The following is a description of a gene set: The pathogenesis of incipient Alzheimer's disease (AD) has been resistant to analysis because of the complexity of AD and the overlap of its early-stage markers with normal aging. Gene microarrays provide new tools for addressing complexity because they allow overviews of the simultaneous activity of multiple cellular pathways. However, microarray data interpretation is often hindered by low statistical power, high false positives or false negatives, and by uncertain relevance to functional endpoints. Here, we analyzed hippocampal gene expression of nine control and 22 AD subjects of varying severity on 31 separate microarrays. We then tested the correlation of each gene's expression with MiniMental Status Examination (MMSE) and neurofibrillary tangle (NFT) scores across all 31 subjects regardless of diagnosis. These well powered tests revealed a major transcriptional response comprising thousands of genes significantly correlated with AD markers. Several hundred of these genes were also correlated with AD markers across only control and incipient AD subjects (MMSE > 20). Biological process categories associated with incipient AD-correlated genes were identified statistically (ease program) and revealed up-regulation of many transcription factor/signaling genes regulating proliferation and differentiation, including tumor suppressors, oligodendrocyte growth factors, and protein kinase A modulators. In addition, up-regulation of adhesion, apoptosis, lipid metabolism, and initial inflammation processes occurred, and down-regulation of protein folding/metabolism/transport and some energy metabolism and signaling pathways took place. These findings suggest a new model of AD pathogenesis in which a genomically orchestrated up-regulation of tumor suppressor-mediated differentiation and involution processes induces the spread of pathology along myelinated axons. Human Gene Set: BLALOCK_ALZHEIMERS_DISEASE_UP species: Homo sapiens from publication Blalock EM, Geddes JW, Chen KC, Porter NM, Markesbery WR, Landfield PW (PMID 14769913) Genes up-regulated in brain from patients with Alzheimer's disease., and this is the list of marker genes: CPSF1, FZR1, APOL2, ZNF202, PTGS1, ZMYM2, EDF1, TENT5A, KAT6A, MITF, TCF7L2, GDF9, KIF2C, NUP98, EPS8, RRBP1, ADGRA3 (adhesion G protein-coupled receptor A3), GPC4, NCSTN, MICB, LAMA2, UPF3A, PIK3C3, HBP1, CHD1, PPP2R5D, SSH3, KCNK5, ARHGEF15, TAF15, TLR1, ZNF268, PDLIM4 (NCBI Gene Id 8572), PPP1R15A, ZNF253 (NCBI Gene Id 56242), PRPF40A, PBX2P1, LAMP1, SPTLC2, SRPX, YY1 (YY1 transcription factor), CYP39A1, CSNK1A1, SNHG14, RBM4B, TPTE, ERP44, SFXN3, PPFIA1 (NCBI Gene Id 8500), MPST, BMPR1A, ELSPBP1, RAC1, LRP6, HDAC1, TAF5, PTP4A2, ADCY7, MAFB, MBP, EXOSC2, ANXA2, HAO2, MAX, RNF24, TNC, COPB1, COL18A1, SLC7A5, TAF11, OFD1, BCL2, RGS9, GBP2, SFSWAP, ZMYM4, TFAP2A, SPAG1, OSER1, SLC13A1, CTDSP2, UCN, ADD3, PNISR (NCBI Gene Id 84956), GYPB, TGFBR3, ZNF133, TTN, PCSK5, ADCY3, SFRP4, RAB3GAP1, GOLIM4, ITGB5, ETV7, PZP (PZP alpha-2-macroglobulin like), PDLIM2, ELK1, GOLGB1, LUC7L3, RER1, FA2H, CXXC1, DMWD, FAXDC2, STARD3, H1-10, ARHGAP17, ZNF195, PDSS2, CALML4, ARIH2, LRRFIP1, MYO1C, QKI, ASB9 (ankyrin repeat and SOCS box containing 9), UROD (uroporphyrinogen decarboxylase), USP48, TYMP, DCLRE1C, SLC25A21, SLC12A3 (NCBI Gene Id 6559), MGC16275, MED13, STAG1, RIMS2, S100A11P1, EGF, PPP6R3, LMBR1L, SETD2, REPIN1, HELZ, ATP8B1, GMPS, CDC14A, FOXO1, JUND, COLGALT2, ABLIM1, CTBS, FERRY3, VAT1, RAD1, ARHGAP1, GPR65, SLC25A40, PFKFB3, LLGL2, ARHGAP6, CCDC22, ITGA1, SMC1A, TCOF1, S100A12, PI4KB, CD22, FBXO11, HSPB8, ASCL1, LZTR1, TRIM38, ADAP1, MADCAM1, ZC3H4, DDR1, DAPK2, KCNMB4, LILRA5, ZBTB10, TEX264, NCOR2, CTNNBL1, EPOR, CAPN3, NONO, MXD4, LARP7, LPP, INPPL1, CD164 (NCBI Gene Id 8763), AKT3, TJP2, IFT74, PTTG1IP, LIMD1, PRP4K, RALY, PECAM1, CLASRP, KDM2A, RNPEPL1, RBBP5, CDH4, GAK, RNGTT, CANT1, PC, CSNK2A2, FNBP1 (NCBI Gene Id 23048), DPH1, DENND2B, SNRNP35 (small nuclear ribonucleoprotein U11/U12 subunit 35), SEMA3C, AGPAT2, MAGEB2, WDR45, STAT6, ZNF43, ZFP36L1, PDCL, JAK3, LIFR, TGFB1I1, MYO5C, IRF7, HRH4, TNFRSF9, MYO1E, TRIOBP, CDC42EP4, C15orf39, EFNA1, SIRT6, PHF20, MRC2 (NCBI Gene Id 9902), GOSR2, LUC7L2, U2AF2, FBLN1 (fibulin 1), ROS1, GGA1, NPEPPS, MACF1, LGALS9 (galectin 9), BMP10, MT2A, GDF1, PDIA4, EIF4B, LRRC1, PLA2G6, PATZ1, MARK3, ANAPC2, PLCG2, CYP3A4, RBM10, CSRP2, ZP3, HLA-E, IFIT5, RASGRP2, RNASEH2A, CHD2, TRIP10 (thyroid hormone receptor interactor 10), NAIP, SCAMP2, PLAAT4, ALDH3A2, LAMC1, JPT2, CCDC59, LSM14A (NCBI Gene Id 91161), ZFAND3, CYP11A1, ITGA10, YES1, CKAP4 (cytoskeleton associated protein 4), GSTM4, TBX6, MT1H, SCAMP3, BMP2K, LHX3, GTPBP3, TCN2, MCL1, AK1, TNFRSF10B, G6PD, CYP2C9, DICER1, IL22RA1, LPAR4, GRK5, FADS3, ACOX3, GAS1, ACAA1, TBC1D2, USP19, NUMB, CUX1, GTF2H1, BCAN, MC1R, R3HDM1, NPC1, TNFRSF11B, SAP25, GUSBP14, SLC6A8 (NCBI Gene Id 6535), MYO1A, TCF7 (NCBI Gene Id 6932), IER2, TMBIM1, BACH2, ARMC8, SECTM1, ZNF160, TGFB2, BCAM, EIF5, RPL13, GNG12, STK11, GALNT6, NKTR, CD37, SPHK1, CLIP2, DYNLT1, ADAMDEC1, ITGB8, UBE2L3, LARP4, IL6, DEFA4, COG2, GADD45B, FUT2 (NCBI Gene Id 93237), HSBP1, HTRA2, PNPLA6, RNASE4, PLXNB2, SMAD5, ARID1A, PPM1F, AP3S2, POLR2H, AP5S1, PHF10, EFEMP2, NUDC, CSDE1, UBXN1, ILKAP, MYLK, GFPT2, KCNN3, TJAP1, USP47, LAT2, THOC1, TRIM44 (NCBI Gene Id 54765), SERPING1, CPQ, RBM6, SNHG20, TM7SF3, TF, DST, MYO6, EEF1A1, G6PC2, CARM1, RAB2A, LGALS14, GMEB2, BTNL3, EIF2B5, TXLNA, HMGCL, ENSG00000275616, GMFB, DAZ1, TSR3, CALD1, GCC1, SSPN, CREBBP, UBE2D4, BIRC2, EEF1G, TIMELESS, AMOTL2, CAPN15, PURA, SEPTIN2, NCAPD2, PRAME, GAGE1, RPS6KA5 (ribosomal protein S6 kinase A5), KDM3A, LGR5, GADD45G, CTBP2, MSX1, HSD17B7, CNPY3, MACROD1, INPP1, MYOM1, NAMPT, ELF4, CCDC69, GPR4, SYNM, GPR162, SLC2A4RG, SREBF2, SMC4, BAZ2B, ZNF84, HSPB2, RNF8, SEPHS1, ELF2, PLAG1 (NCBI Gene Id 7996), UBFD1, LSS, DAO (D-amino acid oxidase), WNK1, DSE, CDR2L, IFI16, IDH2, DSP, PHLDA2, MYO15B, KDSR, SLAMF1, TREX2, CTSS (NCBI Gene Id 50653, cathepsin S), SLC4A7 (solute carrier family 4 member 7), SF3A3, TAGLN, PPP1R13L, KPNA1, SOX12, PRPF6, SRRM2, MAN2A2, ISLR, DGCR6, BCAT2, SLC2A9, PRKAR2A, CFLAR, PPP1R14B, DDX18, ARFGAP2, AGRN, BEST1, MX2, PSME4, MED22, TSPAN32, GTPBP1, SLC4A4, DDX39A, TRIM49, GIPC1, ATP6V1D, PIAS4 (protein inhibitor of activated STAT 4), ARHGEF18, WASF2, ARAP1, TULP3, MLANA, CLEC2B, C4A, TPI1, CMTM6, FEZ2, DDR2, RARB (retinoic acid receptor beta), CTSB, OR2C1 (NCBI Gene Id 81101), BRCA1, PTCRA (NCBI Gene Id 89959), MAP3K14, CRADD, CCR10 (C-C motif chemokine receptor 10), PRCP (prolylcarboxypeptidase), JRK, FAM3A, SUV39H2, TNFRSF1A, KCNJ15, GALNT8, TOM1, ZNF7, PKN1, LEF1, DDX42, ING3, ITIH4, IL18, MAFG, OSGIN2, ZBTB17, DONSON, ZNF337, TAT, DESI2, FBN2, ANP32B, HGF, AVPR1A, SLC38A1, MFAP1, RCC1L, CDK11B (NCBI Gene Id 984), FBXO9, TTTY9A, GGT1, ITGA7, SIRT7, TSPAN31, HAPLN2 (hyaluronan and proteoglycan link protein 2), AOC2, CENPB, SPSB1, NUP205, WWTR1, ZNF24, ENTREP1, CLIC1, PGM3, CSK, NR1D1, TRIM24, MAFF, TNS3, POLR1B, BRD3, PTBP1, HOXC4, GOSR1, TAFAZZIN, DSC3, EXPH5, FLNC, FOXO3, SEC14L2, NT5C, NFE2L1 (NFE2 like bZIP transcription factor 1), NUMA1, AHCTF1, WHRN (whirlin), ASAH1, ZNF83, USP13, RALBP1, PI4K2A, PHF21A, STAU1, TBXA2R, USP7, SLC26A2, CEP350, PDGFB, NIPBL, NKIRAS2, POLR2M, DNAJB2 (DnaJ heat shock protein family (Hsp40) member B2), MAN2B1, RPL13A, TRIP4, SEC11A, NAGA, GPM6B, H2BC21, DIAPH2 (diaphanous related formin 2), EIF2AK2, BHMT2, SERPINA4, MAP3K11, USF2, RRAGD, ECM2, TSPAN6, FAM193A, ZFP36L2, MVK, ING2, EHD1, KLHL20, SPAG9, FKBP8, LMNA, RLN1, SH3BP2, ZMYM5, POU4F2, GSK3B, CA1, TIPARP, INPP5K, GPR107, TNFSF10, APP, ABCD4, CTAGE1, CRKL, CD1D, GOLGA3, FMO2, LPIN1, PCDH9, SLC1A7, HTN1, FBXO2, PARD3, H2AZ2, GABRQ, CD84, HES1, NYX, TNIP1, ZNF277, RHOBTB3, FOXN3, CDC6, USP22, PLAGL2, ATF5, TCF20, ODC1 (ornithine decarboxylase 1), TP53TG5, RC3H2, PGLS, CYTH1, EGFR, GAS2L1, LIPG, COMT, SSR2, RFX4, ARFGAP1, NOP53, MMP12, ADCY2, SP110, ZNF254, HLCS, SART1 (spliceosome associated factor 1, recruiter of U4/U6.U5 tri-snRNP), AAR2, POLRMT, EDAR, UBE2C, TRIM14, MRM3, CCNI, NPAS3, PCM1, NUCKS1, KPNA6, IPP, DDX6, HMG20B, PML, PAH, IQGAP1, GOLGA4, SREBF1, PRKX, RALGDS, FOLH1, H3-3A, SERPINA3, TPD52L1, AFF1, ELAC1, ALDH1A2, TRAK2, COL6A3, AATK, GGPS1, LITAF, IL6R, PILRA, AKR1C3, MGAT1, SEMA4F, MAP4, ZNF131 (NCBI Gene Id 7690), ITPKB, PLOD1, TUBA1A, TPT1, CCZ1, RIN3, POLR3C, CLDN5, KIF3B (NCBI Gene Id 9371), GAMT, IL1R1, ERLIN2, SAP30BP, RXRB, NADK, PTH1R, RAD51AP1, BRS3, SOD2, GBP1, RANBP3, RPL37A, DNAJC4, RBCK1, LIMK2, CRYBG1, RNASET2, PDSS1, PALLD, ELF3, FBXL5, VEGFC (vascular endothelial growth factor C), ARID4A, MBD3, HMOX1 (NCBI Gene Id 3162), SLC33A1, TPD52L2, GAL3ST1, TRPV1, PLSCR3, PIGA, MMP2, CASC3, WWOX, GRB10, AOPEP, AKAP1, C21orf91, MYOT, OGDH, STK38L (serine/threonine kinase 38 like), FAHD2A, EML2, PTBP3, NCOA3, BGLAP, KIF14, CREB3, NCAPG, NR4A3, GMNN, EP400, WIPI2, KHDRBS1, IGFBP5, RBM3, ADGRG2, SGTA (small glutamine rich tetratricopeptide repeat co-chaperone alpha), CLEC7A, FBN1, CUL5, TRIB3, NCAM1, TMBIM6, SENP3, ITPK1, ARHGEF16, SNAPC2, NOTCH4, PSKH1, ERAL1, USP3 (ubiquitin specific peptidase 3), WNT7B, TRIM26 (tripartite motif containing 26), VEZF1, FBXL7, RASGRP3, MTF1, DPYSL3, ITPRID2, RANGAP1, GGCX, CPT1B, ACRV1, DPH5, SAE1, SFRP1, DLX4, DAPK3, TRAM1, CD44, ZRSR2, CHFR, MKRN1, PER2, ZC3HAV1, COL8A2, AGO1, WAS, TCF7L1 (transcription factor 7 like 1), AKAP8L, ZNF473, PDGFRB, GTF2H3, AK2, TFE3, TNFAIP3, ACKR3, PPFIBP2, CD2BP2, PHLDA3, ST6GALNAC4, SHMT2, PDE4C, PBXIP1, NFATC3, PLOD2, SORBS1, NUP214, MALT1, ACADS, POLR1C, KLF1, H2AJ, FLII, USP10, ZNF136, CHRNA10, ALMS1, KLF7, CCHCR1, PAK4, METTL13, PIP5K1A, TUBA3C, ZNF148, SHC1, KCNK10, LMNB1, MSH4, FAM107A, COQ7, NEBL, TFEB, MAB21L2, GAB2, ZFHX3 (NCBI Gene Id 463), PLG, GNAI3, MAPKAPK2, SMOX, TNXA, TSPAN5, H2AX, DDX21, ARPC1B, H2AC18, MAP7, RPGRIP1, SEC22A, ADAM21, SERTAD2, CLEC4M, CRLF1, TNPO1, PRELP, MTHFS, PPIG, MARCHF6, RABGAP1, EFS, HMGXB4, DAAM2, PPDPF, GAST, CASP6, TBL1X, BGN, MED6, H3-3B, SLC35F2, EEF1D, TTF1, PTPA, RBM8A, NFE2L3, NOP14, CD86, CIZ1, TAP1, TNPO3, NGDN, CFHR2, DARS1, NAV2, HDAC4, MKNK2, CEBPA, C3orf18, DUSP9, IRF3, ELOVL6, CAVIN1, WFS1, ZFTRAF1, ID3, GTPBP6, PCDH11X, RPS19, NAP1L1, WWP2, KCNJ14, ST18, BTRC, PLEC, MZF1, ANXA1, DUT, AKR1C1, KIF5B, GLI2, CDC25B, GTPBP8, SCLY, PLIN3, RPLP2, EP300, IFRD2, ZNF12, PAPPA2, SLC35A3, NOSIP, UTP14C, NEK7, BRD2, VPS11, CHST3, ACTR8, B4GALT2, RAMP1, VCAM1, HLA-DRB4, HNRNPA1, PLCE1, MYCN, TOB2, HOXB5, SERPINB4, RALGPS1, CTRL, NEK1, AEBP1, TIMM44, MAPK1, SET, FBXW4, APOC4, GJA1, C5, RAB31, FADS1, GSTM5, NMB, PSG3, THOC2, PLAGL1, ABCA2, IQGAP2, SUN2, NPRL3, TASOR (transcription activation suppressor), APOBEC1, VCAN, PRPF8, SOX9, IL17RA, PIBF1, ZFPL1, LSM5, PPP1R9A, FYCO1, JADE1, DHODH, ADIPOQ, WIPF2, TREX1, PTP4A3, DAAM1, EFEMP1, COL4A3, CDK12, HNRNPUL1, PHKA2, MT1F, SYCP2 (NCBI Gene Id 10388), PABPC3 (NCBI Gene Id 91297), NAP1L4, EIF3B, CSNK1E, ATP7A, SLC19A1, ANG, CTSH, MTIF2, EMID1, RNF216, RSF1, PABPC1, PPP1R1A, SPIB (NCBI Gene Id 6689), CPM, RAB1B, DDX27, NSUN5P1 (NSUN5 pseudogene 1), GSTT2, RAB22A, GPSM3 (G protein signaling modulator 3), SELENOP, SMARCD1, COTL1, RAB13, RREB1, OGG1, ITGB4, NUP43, GEM, TXNIP, USP1, MRPL57, TAX1BP3, CNOT2, LILRA2, A4GNT, CSF1, CTRC, RALA, ITSN1, PIDD1, AZGP1, MCM7, CDKN2C, KLK13, NEK9, SCRIB, RBM38, NCK1, CASP4, NFX1, MUC1, MMP16, CACFD1, CACNA1G, INSR, PRDX6, PDCD4, ZIC1, ABCC10, GJB1, MTMR11, IL15, ZNF180, MET (NCBI Gene Id 4233), SEMA4C, SGK2, EXOSC8 (NCBI Gene Id 11340), BRPF1, AGFG2, PLA2G5, SGK1, PRKD2, TMEM265, KITLG, PPP1CC, OASL, OS9, ZNF358, PRDX3, ERCC6, MR1, BTN3A3, ATP10D, TLE3, CTBP1, CTSL, DUSP22, MAP2K7 (mitogen-activated protein kinase kinase 7), DHFR, AQP1, H2BC5, IL2RG, LYST, MASP1, POP5, VGLL4, RPL4, UBN1, MRAS, CDK13, DAG1, NME3, SEMA4G, TMPRSS3, NME4 (NCBI Gene Id 4833), HADHA, HSP90AA1 (heat shock protein 90 alpha family class A member 1), PCDH17, CRHBP, ANGPTL2, FDFT1, COASY, CBFB, LAMA4, PACSIN2, NOCT, LONP1, PBRM1, AMPD3, SNX6, TRIM10, GTF3C1, IFITM2 (interferon induced transmembrane protein 2), BAZ1A, NQO1, ST8SIA1, SLCO3A1, RPL39, SNTA1, NID1, REC8, MDM1, FGF1, RUNX2 (RUNX family transcription factor 2), PRDM2, HSPBAP1, RRAGC, MTUS1, MOB1A, CDIP1, MUTYH, HERC5, ARHGAP26, HOMER3, MATN2, KPNB1, AQP6, NRXN2, USPL1, BAD, ST3GAL4, C1S, MED1, PSD4, MOCOS, CTDSPL, ABL1, LATS1, RO60, RGS12, STK10, FZD10, TOPORS, DMPK, SUMO3, KDM6A, GUSB, WFDC2, THRA, TUBA8, OR7E2P, KTN1, MAN1B1, TLE4, SLC11A1, EVI2B, CD58, PAX6, TGFB1, CMKLR2, TP53, KAT6B, PTPRK, EPRS1, CPT2, HMBS, PPARD, CR1, FLNA, SINHCAF, HDGF, SYNC, FGL1 (NCBI Gene Id 94993), IGF1R, MED24, ECE1 (NCBI Gene Id 1889), IGSF6, RBMX2 (RNA binding motif protein X-linked 2), GCLC, PSEN2, CCDC9, NFATC1, CLU, H1-2, ADGRG1, RARRES2, MRGBP (NCBI Gene Id 55257), ZNF264, HNRNPM, IL10RB (NCBI Gene Id 3588), RABEP1, ESS2, ARG2, DTNA, MPHOSPH8, CUL4A, ADARB2, PKD1, ASAP3, CNP, SELL, TOP3A (DNA topoisomerase III alpha), TGIF2, TMC6, HIPK2, ZHX3, PIM1, SPSB3, PAK2, CD248, BTG2, TNFAIP8, MAP2K2, ITGB1BP1, MAP3K3, SEPTIN9, ZNF410, LDLRAP1, UNG, PDPN, BIN3, RBMS2, RP2, TAOK2, APTX, UGCG, NFASC, ZNF211, TPD52, COG4, PPM1D, SLC2A1, STOM, PER1, TUBD1 (tubulin delta 1), TTLL3, ACSL1, REST, SOX13 (SRY-box transcription factor 13), TPMT, PDE4D, ZNF175, RYBP, HS2ST1, FGFR3, FICD, IL13RA1 (NCBI Gene Id 3597), GFAP (NCBI Gene Id 2670), AKAP9, PSMC3IP, RPS28, NOP56, ZNF274 (NCBI Gene Id 51732), TRIM68, CAST, SNRK, MYO9B, RHOQ, DLEU1, SRRT, OSBPL11, SERTAD3, IL6ST, SNED1, SNAI2, LDLRAD4, TMT1A, EIF5B, TBC1D5, PPP2R1B, SPEN, DCN, ZNF32, RYK, PRL, VEGFB, TNN, AVEN, ZFHX4, CCND3, NR2F6, NRP2, CASP3, BRD4, HDAC7, SFN, USP4, PDLIM3, CHMP1A, HIP1R, PGAP6, GIMAP5, SAP30, TFEC, IFNA5, ITGA6, HTATIP2, GTF2I, ENTR1, HMGB3, PLOD3, PICK1, TP53AIP1, SLC35C1, APOC1, TAS2R16, SP100, LRCH4, IFRD1, CTDSP1, RFNG, FDPS, PPM1B, LPL, IKZF4, BAZ2A, NDE1, MAPK12, CXCL2, ECI1, SEPTIN6, NAA10, ID4, FANCE, TGIF1, SPARC, ENOSF1 (NCBI Gene Id 55556), GNA12, RPS6KA1, RASL12, NUFIP1, FRAT1, DMC1, TYK2, C7, KAT2B, RBMS3, DBF4, SLC12A9, FXR1, DLG5, DAZAP2 (DAZ associated protein 2), BAG1, HFE, CDK10, PIN4, BTG3, RHBDD3, BIN1, DGKG, LRRFIP2, CD163, PRRX1, ULK2, MAST2, BANP, TLL1, RBPMS, PUM1, SCAF4, TSPO, ZDHHC11, FSTL3, CLEC2D, RPS4X, PHC2, TPRA1, UPF1, ENGASE, SSH1, ERF, UBE3B, NBAS, GTF3C2, HLA-DPA1, FAM50A, ATG3 (NCBI Gene Id 64422), PTDSS2, ANGPT1, KLF2, CASP9, SMARCC1 (SWI/SNF related, matrix associated, actin dependent regulator of chromatin subfamily c member 1), RBMS1, SPAG6, HBEGF, PIK3C2B, SEC62, SP3, GPRC5B, ZNF544, SALL2, CDK2, CPNE3, CDC5L, KBTBD2, VRK3, CDIPT, KIF13B, SMAD4, PTPRF, CHRNA6, GRK6, BCL6, DAZAP1, PITPNC1, SLC25A1, ATG4B (NCBI Gene Id 29918), VRK2, SF3A2, GMPR, TRPS1, USH1C, LGALS3BP, HNRNPH3, HMGN3, RGN, ARAP2, RAB11B, PGC, PXN, REG3A, DHRS9, IL1RAPL1, SRPK2, SUPT20H, NELFA, FTL, CTNNA1, COL4A5, EVI2A, ZNF350, MAZ, POLR1D, SYF2, SIRT2, NR2F1, DIP2A, SLC7A6, RGS16, EDNRA, SEC24C (SEC24 homolog C, COPII coat complex component), AKAP13, SMAD1, DMD, NNMT, ERBB4, ZNF232, PRMT2, MXI1, GALNT10 (NCBI Gene Id 79615, polypeptide N-acetylgalactosaminyltransferase 10), SOX2, CTPS2, N4BP1 (NEDD4 binding protein 1), PPT2, BRD1, LINC02637, ERBIN, IRAK4, CLDN18, SLK, BRAP, SEMA3B, AP1B1, NFIB, ZNF236, PSMF1, PROX1, PAWR, WRN, TAPBP, RASA4, MAT2A, IL10RA, RXRG, GOLGA1, CDC16, COL21A1, ZFP36, GLCE, INSIG1, HEPH, TSPAN2 (tetraspanin 2), SNRNP70, ZMIZ1, LTBP3, FYN, KDM5A, STX5, SNX11, RPL28, SMARCC2 (NCBI Gene Id 6601), COL6A2, MB, CYP4F3, NOP2, ADAMTS9, KLF9, SNAPC1, MYO18A, S100A4, SLC29A2, POM121L9P, CASKIN2, VAMP3, APLNR, SEMA3F, PTGDR2, STIM1, CDK2AP1, PTMA, AGTR1, SNX16, PTPRH, SPOP, SLC22A14, POLH, ZNF444, COL7A1, PEBP1, PIP4K2A, ADH1B, DCAF7, LTBP2, ARHGEF10, EWSR1, NDST1, PLD2, SAV1, TRBC1, GPX3, KMT2A, EPCIP (NCBI Gene Id 84761), TCF3, SLC12A7, AFM, NFIC, NFKB1, UGT1A10, JMJD6, TACC1, SGPL1, ATP6V0E1, MYBPC1, SF3B3, ACVR1B, C1R, MLC1, MT1X, MAP2K3, UVRAG, RBBP6, ZBTB16, ROCK1, ENAH, ASB1, PTCH1, CFAP410, ITPKC, GNAZ, TES, RBM15, JUN, COL1A2, HS1BP3, RPL18, PLCL1, SERPINI2, STAG2, CTNS, SCARB1, GRM6, RPL5, LRP10, RNF19A, PELP1, CGGBP1, EMP1, H4C8, ICAM1, FBXW4P1, SEC24A (SEC24 homolog A, COPII coat complex component), ZNF514, SFTPC, POGZ, APBA3, IRS2, KLF5, DRD2, UST (NCBI Gene Id 10090), FOXJ2, IRAK1, SEC63, PTGIS, GTSE1, RBL1, NEIL1, MYRF, F2R, ABCB6, RPL31, DCP1A, PABPN1, TSC22D4, CDC34, NSDHL, NUP160, CIB1 (calcium and integrin binding 1), SLC14A1, FGFR1, WDR6, EGLN2, HMCES (5-hydroxymethylcytosine binding, ES cell specific), CBLB, GALNT1, NOLC1, ZBTB20, ING4, PHF1, CACNA1A, NEU3 (NCBI Gene Id 10825), PRLR, GUSBP3, KHSRP, MYBL1, RBPJ, LDLR, BFAR, IFNG, DPF3, UBAP2, NTRK3, TRMT1L, SLC35A2, FTH1, NFKBIA, SORD, WWC3, ZC3H7B, ACTL6A, SMAD2, CDKN1C, IFNA7, CASK, USP33, FEZ1, MTA1, GLRA3, ERAP1, CH25H, GCFC2, MYO10, QARS1, LRP4, RUFY1